The following is a description of a gene set: Binding to a growth factor, proteins or polypeptides that stimulate a cell or organism to grow or proliferate. Human Gene Set: GOMF_GROWTH_FACTOR_BINDING studied in species Homo sapiens, and this is the list of marker genes: IGFBP1, NRP2, ACVRL1, COL4A1, PDGFRB, COL2A1, HYAL2, IGF2R, RPS2, IL10RA, GHRHR, ERBB2, IGFBP4, IGFBPL1, IGFALS, FLT4, INSR, LTBP1, FGFRL1, SHC1, SEC61B, FLT1, API5, SCN5A, GPC1, TWSG1, ACVR1C, CSF1R, COL3A1, PDGFB, FBXW7-AS1 (FBXW7 antisense RNA 1), OSMR, PDGFA, CNTFR, RHBDF1, CXCL13, GHR (growth hormone receptor), COL1A2, A2M, FIBP, HAX1, IL36RN, ITGAV, SORT1, ERBB3, IL11RA, IL2RB, IGFBP2, EGFR, CCN1, LTBP2, NKD2, DUSP1, NOG, NGFR, SRPX2, TGFBR3L, ITGA6, FGFBP1, FGFR3, WFIKKN1, LTBP3, ACVR1B, KDR, FGFR4, NRROS, COL1A1, ACVR2B, NRDC, VASN, KL, KIT, GLG1, LRP2, CEP57, TGFBR1 (NCBI Gene Id 7046), CD36, NTRK2, LRG1, FGFBP2, TGFBR2, CCN2, HTRA1, IL1RAPL1, IL1R2, IL2RG, TGFBR3, EPHA2, FGFBP3, BMPR2, FURIN, FLT3, IGFBP3, PCSK6, IL1R1, NTRK1 (neurotrophic receptor tyrosine kinase 1), FGFR2, EPHA7, ENG, COL5A1, TSKU, LTBP4, RPS19, NLRP7, IGF1R, PXDN, NTRK3, WFIKKN2, LRRC32, IGFBP6, IGFBP7, IL1RN, IL9R, NRP1, ACVR2A, CHRDL1, TRIM16, IL6R, ITGB3, S100A13, TGFB3, FSTL4, RHBDF2, ITGB4, IL6ST, IGFBP5, KAZALD1, THBS1, FGFR1, PDGFRA, LIFR, ACVR1, IL2RA, EPHA8 (NCBI Gene Id 2046), HAP1, KLB, COL6A1